Given this list of marker genes ATP6V1F, EMC3, ALG9, SLC38A6, FXYD5, SLC25A30, LGALS8, CREB3L2, RACGAP1, CLEC2B, CLEC4A, PDIA6, SNX5, DNMT1, MRC1, NFE2, TMEM59 (NCBI Gene Id 9528), NDUFB2, LYL1, ANKEF1, PCMT1, MRPL11, MBP, TULP3, RTN3 (NCBI Gene Id 95608), GAS7, RREB1 (ras responsive element binding protein 1), LLPH, PSTPIP1, TCEAL9, PECAM1, LMBRD1, SH3BP5, TRPS1, ZNF331, LGR4, HS2ST1, PCM1, EIF4G3, GLRX5, SH2B2, SFXN3, TMEM144, LAPTM4A, FCGR2A, LMAN2, TST, ITGB1, PSMC2, PTGER2, CHMP2A, SDCBP, RXRA, PPEF2, ZNF468, S100A4, ALDH6A1, TMEM134, SLC19A2, TSPAN3, HIC2, PRKRA, TPP1, KCTD5, KCTD12, HSPA6, RNASET2, LAMTOR2, MOSPD1, SYNC, VAV3, HOXB2, CCDC6, WFS1, TGFBR2, SS18L2, CPA4, ATP1B2, BLNK, ESF1, SOD1 (NCBI Gene Id 6647), RNASE6, CD69, FYCO1, UQCRC1, FES (NCBI Gene Id 2242), SPINT2, CSNK2B, PPT1, PINK1, CCDC69, FKBP4, RNF125, PLPP3, MYCL, TMEM38B, ASGR1, SAMHD1, PAPSS1, RAB1A, FCGR2C, ABITRAM, RAB31, NME4, CD36, FRAT2, POLE3, ENOSF1, MARK1, CDR2L, MLEC, IRAG2, KIAA0930, ARHGAP17, FIRRM, SPG21, GLCE, IL1RN, CAPRIN2, EMP1, EVI2B, CASP1, MOB3B, CCNH, BYSL, GET1, FTL, SLA, TMED2, GABRA2, PRKACB, TMEM147, FCGR2B, SEPTIN9, ATP6AP2, THBD, REXO2, ANG, IL27RA, MAS1, DPEP2, SDC3, PIGA (NCBI Gene Id 5277), KDM7A, LYSET, PRNP, ARPC5, NCSTN, BLZF1, CAT, BLVRB, DECR1, SFTPD, HEXA, WDR12, KLF4, ATP5MC3, ZFP36L2, RRAGD, SLC9A6, HDDC2, C11orf21, RNASE4 (ribonuclease A family member 4), HEXB, PDXK, OSBPL1A, SDC2, DAB2, PRND, CPD, TENM1, ATP13A2, SLCO1B3, CD302, GPD1L, MRPL15, TPST2, AP3S1, TECR, MRTFB, MAP3K5, GMFG, CPQ, ACBD3, OSBPL11, MPRIP, OR7E47P (olfactory receptor family 7 subfamily E member 47 pseudogene), GPR35, EPAS1, SEPHS2, NAGA, S100PBP, NAIP, RNF13, CYB5R1, FCER1A, ADORA2B, CCND3, PDLIM2, here is a description of the gene set: Human Gene Set: GSE45365_NK_CELL_VS_BCELL_MCMV_INFECTION_UP Murine Cytomegalovirus (MCMV) infection leads to early activation of various immune cells, including B and T lymphocytes, before the actual initiation of antigen-specific adaptive immunity. This activation is partly driven by innate cytokines, including type I interferon (IFN), which are induced early after infection. The objective of this study was to address the role of type I IFN in shaping early/innate B and T cell responses to a primary acute viral infection. In order to decipher the specific impact of IFN-I on cell subsets, we performed a genome-wide expression analysis on WT splenic B and CD8 T lymphocytes isolated from C57BL/6 mixed bone marrow chimera mice. This study complements series GSE39555, which focused on early responses of NK cells and of the two subsets of conventional dendritic cells. studied in species Homo sapiens Genes up-regulated during primary acute viral infection: NK cells versus B lymphocytes.